Given this list of marker genes SDHD, KIF1B, DBH, SLC6A2, MYCN, SDHAF2, DLST, DNMT3A, PHOX2B, SDHA, HACE1, SDHC, TMEM127, SLC25A11, LIN28B, NF1, LMO1, SLC18A2, EPAS1, MDH2, CCND1, VHL, ALK (ALK receptor tyrosine kinase), SDHB, FH, RET, MAX (NCBI Gene Id 4149), here is a description of the gene set: An abnormal amount of urinary catecholamine concentration. species: Homo sapiens Human Gene Set: HP_ABNORMALITY_OF_URINE_CATECHOLAMINE_LEVEL Abnormality of urine catecholamine level